Given this list of marker genes CNBP, COX4I1, UBE4A, CFDP1, MDH1, UGP2, ATP5MF, MYL11, SAP18, SKP1, SYPL1, DNPEP, NDUFS1, MBD4, SETD3, URM1, COX7A2L, UQCRB, TMED2, LAMP2, SMG7, NDUFA2, RALBP1, AP2M1, NEDD8 (NEDD8 ubiquitin like modifier), CTCF (CCCTC-binding factor), UTP18, EIF4E2, IST1, ATP5F1C, SPTLC1, PSMC1, RAD21, RNF115, RNF6, RAB5A, PPP6C, HARS2, ATP6AP2, SEC13, HADHB, PDCD6, COX5A, SLC35A1, FAM120A, CNIH1, SEM1, EBAG9, COPB1, COPS5, CTBP1, HSBP1, UBR5, STX16, CD47, BAG5, GMFB, GABARAPL2, CANX, DYNC1I2, YWHAB, YY1, PSMD7, PSMA4, PSMB4, PPP1CA, PSMA3, PPP1R7, CLEC18C, URI1, PSMC2, PRKAR1A, ADAR, SUMO1, NDUFA1 (NADH:ubiquinone oxidoreductase subunit A1), ENSA, KARS1, SRP9, TBCA, SRP19, MTDH, BUD31, RAD23B, PSMC6, FAM20B, here is a description of the gene set: species: Homo sapiens Human Gene Set: MORF_MBD4 Neighborhood of MBD4 Neighborhood of MBD4 methyl-CpG binding domain protein 4 in the MORF expression compendium